Given this list of marker genes Itgav, Itgb3, Pcsk9, Adipoq, Abca2, here is a description of the gene set: Any process that stops, prevents or reduces the frequency, rate or extent of low-density lipoprotein receptor activity. studied in species Mus musculus Mouse Gene Set: GOBP_NEGATIVE_REGULATION_OF_LOW_DENSITY_LIPOPROTEIN_RECEPTOR_ACTIVITY